The following is a description of a gene set: species: Homo sapiens Human Gene Set: GOBP_REGULATION_OF_EXTRACELLULAR_MATRIX_DISASSEMBLY Any process that modulates the rate, frequency or extent of extracellular matrix disassembly. Extracellular matrix disassembly is a process that results in the breakdown of the extracellular matrix., and this is the list of marker genes: FGFR4, FAP, FSCN1, CLASP1, MIR205, CLASP2, CST3, TIMP3 (NCBI Gene Id 7078), DPP4, TGFB1, MIR29C, MELTF, IL6, MIR29B1, MIR195, DDR1, CARMIL2, TGFB2, RECK, PDPN, LRP1, STAT3, MIR92A1, MIR98, DDR2, MIR24-1 (microRNA 24-1)